The following is a description of a gene set: Genes predicted to be targets of miRBase v22 microRNA hsa-miR-374b-5p in miRDB v6.0 with MirTarget v4 prediction scores > 80 (high confidence targets). studied in species Homo sapiens Human Gene Set: MIR374B_5P from publication Chen Y, Wang X (PMID 31504780), and this is the list of marker genes: MBNL3, PLD5, RSF1, GADD45A, N4BP2, TNFAIP3, WNT5B, RNF14, SMAD2, RALGPS2, LCA5, PHACTR2, CYP24A1, MYO5C, TMEM123, GNB2, FLG2, PRDM11, AHSA2P, GNPNAT1, CCNE2, CYB5A, RNF214, ABCA8, XIRP2, NKX2-2, MAP4K3, OCRL, CWC27, CCDC34 (coiled-coil domain containing 34), EXOC5, RAB22A, MSI2, EN1, NUP35, PSMC3IP, TMED5, ARHGAP5, BEND4, SOS1, ADD3, SHPRH, CSMD3, RBM27, AAK1, LEPR, MAP2K6 (mitogen-activated protein kinase kinase 6), FZD3, TAF4B, MICB, CSGALNACT2, DCAF10, NTF3, TM4SF19, CACNB4, RREB1 (NCBI Gene Id 6239), STEAP2, HNMT, C11orf87, DUSP6, CDK6, PRR16, NIBAN1, ZCCHC4, HIBADH, ETS2, ASTN2, TAF5L, DSG2, HMGN5, PIGW, EDAR, FAM47E-STBD1, SEMA3D, FAM161A, NDUFA5, ZNF655, TACC1, TMEM192, TCAIM, DUSP8, PDCD1, ZNF81, DOK6, HSBP1, SLC35F5, NEUROG2, OR7A5 (NCBI Gene Id 55551), ZIC3 (Zic family member 3), CELF4, KLHL29, MCTP2, CCDC47, MYO5A, MOSPD2, CDS1, RPRD2, PDE7B, CGNL1, ZDHHC5, ACSL6, ADAM10, CCDC191, HAPLN1, TMEM245, TCF24, CEP350, KIRREL1, KAT6A, AHDC1, PAPPA (pappalysin 1), RELCH, MAP9, MAPK6, RAP1B, FRMPD4, MOCS3, MIPOL1, CCL2, IQSEC2, NCK1, CDC14A, ASCL1 (achaete-scute family bHLH transcription factor 1), RFK, ELAVL4, WASHC4, FGF5, CCND1, PCDH11X, SLITRK1, RGS7BP, DBR1, MCFD2, BOLA3, MBLAC2, MZT1, TENT2, PMPCB, TLE4, LNPK, FBXL5, CADM2, NRDE2, GOLGA8M, TGFA, ATF7, PCDH11Y, PRH2, CENPJ, LPAR1, RPL34, AHR, C8orf33, GRAMD1B, NCOA1, TRPS1, NEDD4L, SP5, ZBTB46, RNF180, WDR72, FABP2 (fatty acid binding protein 2), AFF1, PPIL3, RORA, TM9SF2, TCERG1, SMARCAD1, HECTD4, FPR3, RALGDS, ASB5, PDE10A, TMEM207 (NCBI Gene Id 131920), ANLN, ANTXR1, UBE2K, GABRA1, FOXD2, DMXL1, SLC2A12, FNIP1, ZNF527, MYO5B, LTBP1, ACKR4, HGF, SP4, PELI1, KCTD20, MMP14, EYS, SRSF7, TMEM108, TMEM38B, FAM222B, POLK, MICU3, GABRG1, KIF20A, DCUN1D1, ABAT, IL22, GAS7, IKZF2, CAV2, SGPP1, CYYR1, SP1, RGS4, LSAMP, NUP98, ZNF131, VSTM2A, HOXA10, RTKN2, MAP2, AHI1 (Abelson helper integration site 1), PDE4D, WDR35 (WD repeat domain 35, NCBI Gene Id 57539), IGFBP3, EEA1, CNTN1, UBE3A, SNX18, STMN2 (NCBI Gene Id 11075), CAMSAP2, TXLNB, PLN (phospholamban), YME1L1, MREG, LRRTM3, EPB41L2, NRK (NCBI Gene Id 203447), STYX, FAF2, ZNF711, NRG2, NGLY1, TAFA2, NLN, HSPA4, ANKRD34B, VEGFC, CLVS2, TMEM185A, SMAD6, UST, ZFP37, VGLL3, NHLRC2 (NCBI Gene Id 54835), DCDC2, SPIN1, CAPZA2, HOMER1, GPANK1, CNTN4, TET3, ACVR2B, DSEL, ZNF587B, HUNK, GCLM, MACC1, TSPOAP1, SLC22A10, PKD1L2, PITX2, TBC1D23, RGS21, STK38L, NUDT11, PEX2, NEO1, ZNF280D, RIC1, RAB3GAP2, ZNF16, RABEP1, ACAN, SEPSECS, HES1, PGGT1B, MED13, PRDM5 (PR/SET domain 5), FDXACB1, CDC42BPB, BMP2, ADCYAP1, TBC1D9, NR4A3, PAQR3 (progestin and adipoQ receptor family member 3), TMEM267, MIS18A, HR, LRP12, PNLIPRP3, ZCCHC9, CRIM1, PSMB2, RAC1, TMPRSS11B, GABRG2, MEF2D, MECP2, ZNF615, NETO1, NSUN3, SYT14, ACSL4, TNRC6A, GATA3, EXOC7, TFDP1, ATXN1, ITGA2 (integrin subunit alpha 2), SEL1L, ABHD5, TMEM196, PTGER3, PRDM1, LIN9 (lin-9 DREAM MuvB core complex component), C11orf58, SUCNR1, LDLRAD4, KLHL28, PARD6B, SPOPL, NIPBL, TTC8, STBD1, AGPAT5, ETNK1, ZBTB34, PRPF18, YTHDF1, MLX, SNX4, APOBEC4, NME5, SLIT3, SP3, DUSP19, ZNF423, HECTD1, ZSWIM6, FOXM1, PDE4B, CEBPB, CCL8, TBC1D19, BRWD3, WNT5A, PREX2, PLPP3, SCML1, LIN54, CXADR, GLO1, PRRG1, ATAD2, SUMO4, EN2, CAAP1, CCDC126, SCRN3, SRSF5, MORN4, CEMIP, EIF2S2, MKX, ABHD18, PARP8, PCDHB15, AGL